The following is a description of a gene set: The aim of this study was to quantify the impact of chimeric Foxp3-GFP protein on the Treg cell transcriptional program. Genes up-regulated in T reg (FOXP3+) cells from B6 mice: Foxp3-Fusion-GFP versus Foxp3-ires-GFP. species: Homo sapiens from publication Darce J, Rudra D, Li L, Nishio J, Cipolletta D, Rudensky AY, Mathis D, Benoist C (PMID 22579475) Human Gene Set: GSE37605_FOXP3_FUSION_GFP_VS_IRES_GFP_TREG_C57BL6_UP, and this is the list of marker genes: CEBPD, RNF19B, SPRY4, ZFP36, SLC10A6, HMGCS2, SLC25A25, CXCL2, KCNK13, ST3GAL3, C2, MRM3, SNX7, MED24, NBL1, ACO2, NUAK2, MUC13, BAMBI, FOSL2, EDN1, CMKLR1, LRRN3, PER1, TSPAN12, PVR, SPRY1, PADI2, MYC, VPS37B, TM4SF1, HOXA5, H6PD, DGAT1, TGFB1I1, DST, FOSB, RAB43, BTG2, CYYR1, JUP, JUNB, PRSS3, PPT2, TNFSF18, NDRG2 (NCBI Gene Id 57447), KLHDC10, SIK1, NTF3, PLXDC1, PLK3, DUSP5, OSTF1, CD151, FAM76A, PLD1, CNTFR, SLCO2B1 (solute carrier organic anion transporter family member 2B1), SELENON, PJA1, HEATR5A, CSRNP1, CASP7, CNKSR3, ADAMTS1, WBP11, CREM, ADPGK, ANGPT2 (NCBI Gene Id 285), SERPINE1, RASGEF1B, TMEM106A, ITGB5, PLAUR, TRIM25, TM9SF4, CEBPB, IER3, LRP5, NR4A3, TPM1, SGK1, GSTA4, TNS1, MAFF, ID3, THBS1, FLVCR2, PTPRM, CCL24, CD93, ISY1, FOXN3, TMEM45A, ARL5B, LATS2, ADHFE1, ACKR3, FKBP9, KALRN, SDC4, EAF1, DUSP1, MIR10B, TNS2, DUSP6, PPP1R15A, EGR1, USP21, DLL1, PHKA2, CH25H, KCNE4, PDE4D, ARL4D, PLK2, BLOC1S3, RCAN1, MINDY1, DCLRE1B, GTF2IRD1, MFHAS1, PRDX6, FKBP7, CCL2, JDP2, TC2N (tandem C2 domains, nuclear), EYA1, EID3, OXNAD1, MT1A, NR4A1, ADM, MIR145, AGRN, INPPL1, HS3ST1, WWC2, WT1, RDH10, AKAP12, ATF3, UXS1, JUN, SPRY2, PMF1, RASL11B, FOS, CCN2, ZFYVE9, EYA2, ETS2 (ETS proto-oncogene 2, transcription factor), CHST15 (NCBI Gene Id 9916), IPMK, EGFR, SLC16A7, GEM, EGR2, ASCC1, BLVRA, FZD7, NR4A2, DAPK1, SCARB1, IL1A, PTGS2, GAB1, SLC25A33, SNTB2, NFIA, AGTRAP, SLC24A3 (NCBI Gene Id 96617), FRRS1, CCRL2, HOMER1, APOLD1, ID1, SVEP1, F11R, RND3, KDM6B, HBEGF (NCBI Gene Id 1839), NAV3, ESAM, TMCC3